The following is a description of a gene set: from publication Yagüe E, Arance A, Kubitza L, O'Hare M, Jat P, Ogilvie CM, Hart IR, Higgins CF, Raguz S (PMID 17283147) Resistance to chemotherapy is one of the principal causes of cancer mortality and is generally considered a late event in tumor progression. Although cellular models of drug resistance have been useful in identifying the molecules responsible for conferring drug resistance, most of these cellular models are derived from cell lines isolated from patients at a late stage in cancer progression. To ask at which stage in the tumorigenic progression does the cell gain the ability to acquire drug resistance, we generated a series of pre-tumorigenic and tumorigenic cells from human embryonic skin fibroblasts by introducing, sequentially, the catalytic subunit of telomerase, SV40 large T and small T oncoproteins, and an oncogenic form of ras. We show that the ability to acquire multidrug resistance (MDR) can arise before the malignant transformation stage. The minimal set of changes necessary to obtain pre-tumorigenic drug-resistant cells is expression of telomerase and inactivation of p53 and pRb. Thus, the pathways inactivated during tumorigenesis also confer the ability to acquire drug resistance. Microarray and functional studies of drug-resistant pre-tumorigenic cells indicate that the drug efflux pump P-glycoprotein is responsible for the MDR phenotype in this pre-tumorigenic cell model. species: Homo sapiens Human Gene Set: YAGUE_PRETUMOR_DRUG_RESISTANCE_DN Down-regulated genes common to all pretumorigenic cells with acquired drug resistance., and this is the list of marker genes: FRMD4A, TRAM2, VCAN, TNS1, MMP2, SEPTIN11, DSE, LTBP2, COL8A1 (collagen type VIII alpha 1 chain), RREB1, CALD1, ACAN, DCHS1